Given this list of marker genes HELLS, STING1 (stimulator of interferon response cGAMP interactor 1), KRTAP10-4, PAQR5, ANXA13, MSR1, CYP2R1, XRCC4, TPPP2, KYNU, HOXC6, FNBP1L, FIBIN, VPREB1, LSP1, NQO1, RCBTB2, GABRB2 (NCBI Gene Id 2561), FAM118B, DNAI3, SDK2, ADRA1B, MIR450B, FREM2, MARCHF1, SLCO4C1 (solute carrier organic anion transporter family member 4C1), ALG12, TMPRSS11A, ADGRG5 (NCBI Gene Id 221188), CYFIP1, B9D1, GALNT14, PCDHB10, LILRB3, MIR653, GUCY1B2, ITGB8, FTO, SSR1, WARS1, BRD8, KCTD6, PDZK1IP1, ANKRD45, ZMPSTE24, DIMT1, PEX11A, MTMR14, C14orf39, PLA2G12B, PDCD1LG2, RAB27B, SPINT3, CD14, CMTR2, PGLYRP1, GTPBP10, LILRB4, FUS, NAT1, MT1A, RBM24, PGLYRP4, CGA, ENO1, MLPH, ORM1, GAREM1, TMEM35A, RPAP2, LIPE, GLUL, SOX1, ADGRF1, BEX1, LRRC52, INTS4, ENO4, CAPZA2, CTNNA1, CLIP4, IQCF1, ISG20, TSLP, LGI2, PADI1, LRRC19, RNF121 (NCBI Gene Id 95997), KLHL23, TGM2, PDE9A, ANGPT4, GGTA1, CNTNAP4, MIR495, GNG2, CCDC3, ABHD10, MIR7-1, MMAA, CFAP58, SCTR, PRTN3, CABLES2, KLHL13 (NCBI Gene Id 90293), TBC1D5, PGD, LSG1, CTH, KREMEN2, TMEM198, ALDH3B1, CCKBR, HTR3A, GNA15, COX5B, TMPRSS13, here is a description of the gene set: Genes down-regulated in vascular smooth muscle cells: control versus treated with IL17A. Investigate the effect of recombinant human IL-17A on vascular smooth muscle cells cultured from human aortas. studied in species Homo sapiens Human Gene Set: GSE11367_CTRL_VS_IL17_TREATED_SMOOTH_MUSCLE_CELL_DN from publication Rao DA, Eid RE, Qin L, Yi T, Kirkiles-Smith NC, Tellides G, Pober JS (PMID 19075290)